The following is a description of a gene set: This event has been computationally inferred from an event that has been demonstrated in another species.<p>The inference is based on the homology mapping from PANTHER. Briefly, reactions for which all involved PhysicalEntities (in input, output and catalyst) have a mapped orthologue/paralogue (for complexes at least 75% of components must have a mapping) are inferred to the other species. Reactome Pathway: Enzymatic degradation of dopamine by COMT electronically inferred by orthology from the curated human pathway species: Mus musculus part of: Dopamine clearance from the synaptic cleft, and this is the list of marker genes: Tomt